The following is a description of a gene set: species: Homo sapiens Autophagy is an intracellular degradation process that is triggered by cellular stresses. There are three primary types of autophagy - macroautophagy, chaperone-mediated autophagy (CMA) and late endosomal microautophagy. Despite being morphologically distinct, all three processes culminate in the delivery of cargo to the lysosome for degradation and recycling (Parzych KR et al, 2014). In macroautophagy a double membrane compartment sequesters the cargo and delivers it to the lysosome. Chaperones are used to deliver specific cargo proteins to the lysosome in CMA. In microautophagy invaginations of the endosomal membrane are used to capture cargo from the cytosol. Autophagy can target a wide range of entities ranging from bulk proteins and lipids to cell organelles and pathogens giving rise to several subclasses such as mitophagy, lipophagy, xenophagy, etc. (Shibutani ST 2014 et al). Reactome Pathway: Autophagy, and this is the list of marker genes: WDR45B, MTMR3, PRKAG3, VCP, RB1CC1, ARL13B, DYNC1H1, TUBB1, ATG14, PIK3C3, CSNK2A2, UBE2D3, MTOR, UVRAG, TUBA4B, ATG16L2, TUBB2A, CHMP4B, HSF1, UBE2D2, HDAC6, TUBAL3, RPTOR, LAMTOR1, TUBB4B, GABARAPL3, CETN1, CSNK2B, MTERF3, MAP1LC3B, TUBA1A, CHMP2A, GABARAP, TUBB4A, GABARAPL2, ATG4A, PARK7, PEX5, UBC, CHMP4A, TUBB3, OPTN, TOMM7, UBA52, TUBB8, PGAM5, PRKAG2, TUBA3D, GFAP, SQSTM1, MVB12A, ATG101, VDAC2, TUBA4A, TOMM40, ATG13, CHMP7, DYNC1LI1, TSC2, BECN1, UBE2N, VIM, PLIN2, MAP1LC3C, HSPA8, CHMP3, IFT88, TSG101, PCNT, ATG16L1, UBE2L3, SRC, ATG9B, TSC1, VPS37D, TBK1, LAMP2, CSNK2A1, VPS28, MVB12B, MAP1LC3A, PINK1, PRKAG1, DYNC1I2, TUBB6, WIPI2, NBR1, HBB, ULK1, TOMM6, LAMTOR2, DYNC1I1, TUBA3C (NCBI Gene Id 7278), UBAP1, ATM, CHMP2B, TOMM20, DYNLL2, ATG10, HSP90AB1, VDAC1, RPS27A, RHEB, GABARAPL1, MFN1, FUNDC1, MTMR14, ATG4B, TOMM5, ATG7, TOMM70, ATG4D, RRAGC, RNASE1, RRAGA, ATG4C, AMBRA1, LAMTOR5, TUBB8B, TOMM22, RRAGB, MFN2, TUBA1C, EPAS1, PLIN3, CHMP4C, ATG3, TUBA3E, PRKAB1, PIK3R4, SLC38A9, PRKN, TUBA1B, RRAGD, LAMTOR4, VPS37C, PRKAA1, CFTR, DYNC1LI2, EEF1A1, PRKAB2, UBE2V1, TUBB2B, WIPI1, TUBA8, HSP90AA1, MLST8, DYNLL1, ATG9A, CHMP6, ATG12, ATG5, USP30, VPS37B, LAMTOR3, VPS37A, VDAC3, PRKAA2, WDR45, UBB